Given this list of marker genes UCP2, SLC25A13 (solute carrier family 25 member 13), SLC1A4, SLC25A12, SLC1A2, SLC1A1, SLC1A3, SLC1A6, SLC25A22, SLC1A5, SLC25A18, here is a description of the gene set: species: Homo sapiens The directed movement of L-aspartate across a membrane by means of some agent such as a transporter or a pore. Human Gene Set: GOBP_L_ASPARTATE_TRANSMEMBRANE_TRANSPORT